Given this list of marker genes Chd3, Ermard, Mif4gd, Fmn2, Fos, Lypd1, Tm9sf3 (NCBI Gene Id 67221), Cep78, Plekhg1 (pleckstrin homology domain containing, family G (with RhoGef domain) member 1), Dnaaf9, Ccndbp1, Pisd-ps1, Tmem108, Cercam, Klhl5, Impa2, Itgb8, Shroom2, Mllt3, Mapre1, Elavl3, 1700028E11Rik, Kansl1, Bak1, Map1b, Eya3, Gm49083, Ppm1l, Cklf, Mical3, Tctn2, Cib1, Jun, Hdac9, Sox8, Slc41a2, Mir1949, Stat1, 1700047M11Rik, Pcdh19, Ebf4, Gnptab, Usp53, Pdk1, Foxp1, Tet2, Reno1, Cdh20, Ulk2, H1f2, Card19, D630045J12Rik, Grb14, Bfar, Plekhm3, Lrrc75a, Tyro3, Sorbs1, Rhobtb3, Nkd1, Gjc3, Smurf1, Thoc2l, Ddx23, Plpp6, Prkcq, Nkain1, Inava, Sec16b, Ninj2, Ankrd44, Hnrnpr, Rnf128, Ecpas, Syt1, Wwp2, Tmem63a, Atp6v1g2, H3c14, Trip11, Slc1a3, Ndufaf3, Nrtn, Fam174b, Sv2a, Ehd1, Eef1akmt2, Rbm25, Fam13c, Lats2, Svil, Pde4b, Amn1, Rcor2, Tmeff1, Pdgfc, Frmd4b, Epb41l1, Tpp2, Sdsl, Psmf1, Ifi27l2a, Prrc2c, Aar2, Mbnl2, Bmp1, Shb, Rnf144a, Ucp2, Ipo7, Snrpd3, Atat1, Kctd18, Slc45a4, Plekhn1, Gpr37, Hbp1, Mxi1, Nr1d2, Thtpa, Prune1 (NCBI Gene Id 77902), Atp1b2, Tcf12, Ift22, Kctd4, Bnip3, Zfp24 (zinc finger protein 24), Lman1, Ier5 (NCBI Gene Id 15939), Hand2, Wwp1, Gdi1, Chml, Htt, Mir100hg, Klhl29 (NCBI Gene Id 208439), Arhgap5, Frat2, Rbm12, Fbxo6, Cyfip2, Tmc7, Gnb4, Apba1 (NCBI Gene Id 56090), Gm20515, Efhd1, Rtn4, Map6, C1qtnf5, Rffl, Casp6, Myo1g, Sass6, Sgk2, Terf1, Ttbk1, Sat1, Sgpl1, Jcad, Dusp10, Bmerb1, Rttn, Igfbp7, Dalrd3, 1600012H06Rik, Mpv17, Soat1, Tnfrsf21, Ptprm, C4b (complement C4B (Chido blood group)), Sox21, Atg4a-ps, Bcas1, Tgfbr3, Lmbrd1, Rhog, Tbx2, Narf, Jak2, H2bc4, Foxp2, Ppp1r21, 9630013A20Rik (RIKEN cDNA 9630013A20 gene), Tmem8b, Tlk2, Mindy1, Cert1, Zbtb20, Tmem198b, Ostm1, Has2, Fam234b, Arhgef25, Fkbp8 (NCBI Gene Id 14232), Sdc2, Cnp, Dnajb14, Mau2, Pxdn, Mpdu1, Ndrg1, Ppp1r12b, Rabgap1l, Aldh3b1 (aldehyde dehydrogenase 3 family, member B1), Sae1, Ehbp1, Cela1, Ubfd1, Omg, Wrn, 1810037I17Rik (RIKEN cDNA 1810037I17 gene), Mutyh, Snorc, Apba2, Lgals9, Wipi1, Kdm5b, Rasgef1b, Pcdhb7, Cpt1a, Vps51, Slc15a4, Sap30bp, Lrrc42, Msi2, Tmco6, Frmd5, D16Ertd472e, Cadm1, Zfp809, Gen1, H4c9, Zfp637, Tmem88b, Dtna, Dock4, Cdv3, Baz2b, Amd-ps1, Pex1, Atp8a1, Ccng2 (NCBI Gene Id 12452), Lpgat1, Ldlrad3, Pkig, Tgs1, Smarca2, Mylk, Cyb5a, Pdzrn4, Mt3, Aopep, Deptor, Cfap410, Myo18a, Pvt1, Tmem35a, Tppp, Hira, Shisal1, Tnr, Slc16a7, Gdf1, Tmem150a (transmembrane protein 150A), Wdr35, Lhpp, Armc6, Cep192, C1galt1c1, Cdc37l1, Car14, Mdp1, Vwa5a, Inpp5e, Inppl1, Pcdhgc4, Rundc3a, Astn1, Wdfy1, Serpini1, Herpud2, Ccnt2, Slc30a1, Actb, S100a1 (NCBI Gene Id 99575), Coro1c, Pigg, Plxnc1, Gria2, Agpat4, Chpt1, Stxbp3, Mtmr4, Wdr1, 1700039M15Rik, Fbxo32, Cers6, Ptgds, Slc31a2, Abcd4, Syt4, 2610021A01Rik, Tcf7l2, Map4k5, H3c15, Sorbs3, Ccpg1, Atg13, Zdhhc12, Chic1, Unc5b, Invs, Kif13a, Srgap1, Fkbp15 (NCBI Gene Id 338355), Hmx2, Bche, Ssc5d, Slc26a2, Tmcc2, Ptpdc1, Ylpm1, Cpsf6, Pmel (premelanosome protein), Tmsb15l (NCBI Gene Id 399591), Tbc1d14, Plxnb1, Gmfb, Hspa4, Mapre3, Plxnb3, Txnip, Nbeal1, Marcks, Rictor, Col11a1, Brsk1, Kif3c, Kif1b, Sema4g, Marf1, Nav3, Abcc10, Mgme1, Rad54b, Creld1, Slc6a6, Fancb, Fbxo10, Col6a1, Srcin1, Aebp1, Stk11ip, Tmbim1, Dixdc1, Zscan29, Serinc5, Btg1, Pcmtd2, Mospd2, Sat2, Dcc (DCC netrin 1 receptor), Mark1, Hsdl2, Gm20300, Hip1r, Cers4 (NCBI Gene Id 67260), Dzip1, Syne1, Ccdc28a, Klf13, Tbc1d22a, Ezr, Pcdhb17, Prtg, Pard6g, Pfn2, Parp3, Depdc7, Mastl, Usp20, Slc25a42, Epb41l4b, Ralgps2 (NCBI Gene Id 98645), Reps2, Aspa, Phldb1, Spag4, Hey1, Coq8a, Lbp, Stmp1, Cpm, Pnisr, Nol4l, Map6d1, Wac, Fam241a, Skil, Acy3, Wls, Fam120aos, Ddhd1, Ccdc13, H2ac18 (H2A clustered histone 18), Dscam, Mob3b, Fam193a, Sft2d3, 4933427D14Rik, Myo6, Bfsp2, Itga7, Snx5, Enpp2, Sik1, Pdlim7, Matn2, Lcorl (NCBI Gene Id 338482), Tns1, Golph3l, Btbd17 (BTB domain containing 17), C630043F03Rik, Tmem80, Tmcc3, Malat1, Pex5, Abhd10, Cabin1, Arrdc3, Tpgs2, Prag1, Rapgef1, Rassf2 (Ras association (RalGDS/AF-6) domain family member 2), Syngr1, Kalrn, Hells, Bin3 (NCBI Gene Id 80552), Hs3st1, 4930452G13Rik, Zfhx3, Miga2, Tnrc6b, Tomm20, Sorl1, Serpinb8, Hectd4, Tmeff2, Tnfsf9, Abhd3, Jam2, Rbm18, Dipk1a, Reln, Ablim1 (actin-binding LIM protein 1), Lrig1, Prkar2a, Mbp, Tubb4a, Epha7, Pnn, Adgrl3, Dnmt3a, Eldr, Per3 (NCBI Gene Id 72717), Yipf4, Ercc1, Glrb, Negr1, Bcl2l12, Slc35a3, Efr3b, Coq3, Rusc1, Gatm, Nsd2, Lin54 (lin-54 DREAM MuvB core complex component), Tsc22d1, Ino80dos, Zfyve27, Gnao1, Atosb, Sgcb, Rtl8c, Dner, Glis2, Slc25a27, Trp53inp1, Cfl2, Pik3r3, Pigb, Serbp1, Bace1, Ikzf5, Dennd5a, Slc44a1, Cops9, Nasp, Fcgrt, Iqce (NCBI Gene Id 74239), Golga4, Wdr83, Klhl2, Entpd5, Tube1, C1ql3, Glis3, Capn6, Col6a2, Thsd7a, Elovl7, Klhl18, Gng7, Mfsd12, Hlf, Slc5a3, Rab40c, Mex3b (NCBI Gene Id 93845), Slc48a1, Snx30, Col16a1, 3110040M04Rik, Cdc42ep5, Cenpw, Antxr2, Gpr180, Cep295, Dnm3, Chmp1b, Htra3, Retreg1, Fgfr2, Akt3, Lrrc8c, Pde9a (NCBI Gene Id 18585), Sdc1 (NCBI Gene Id 20969), Mllt11, Phldb2, Rab3gap2, Col9a1, Prickle1, Ndnf (neuron-derived neurotrophic factor), Qpct, Padi2, Ncam2, Usp6nl, Pacs2, Vmac, Ltbp1 (NCBI Gene Id 77322), Kifc2 (NCBI Gene Id 223662), Adamts4, Mroh3, Slc13a4, Pip4k2c, Lhfpl6, Zdhhc14, Col27a1, Jrk, Ncan, Asic1, Mapt, Zeb2, Ankrd12, Arsb, Kcna1, Pdcd4, Zfp445, Ccsap, Snapin, F8a, Col4a6, Ncor1, Slc17a5, Ndor1, Nherf2, 6030400A10Rik, Gsk3b, Tcta, Fyn, Tnfaip6, Ado, Dusp8, Pdlim2, Sema5b, Kctd13, Aatk, Septin4, Mapk8ip3, Fmnl2, Smg5, Timp2, Arhgap42, 5430435K18Rik, Mpzl1, Dlgap4, Atxn7l2, Nmral1, Tra2a, Slc1a1, Slc22a23, Arl5b, Rab7b (RAB7B, member RAS oncogene family), Purg, Osbpl9, Arl4a, Reck (reversion-inducing-cysteine-rich protein with kazal motifs), Dbn1, Irgm1, Myrf, Dusp7, Tmem19, Cdc42ep3, Chadl, Crebrf, Chd4, Ulk1, Kank1, Ttc5, Csf1, Atf3, Dct, Ptprcap, Fbxl3, Mb21d2, Vps37b, Pisd-ps2, Dynlt3, Cryab, Ppp1r16b, Gipc1 (NCBI Gene Id 67903), Parm1, Galc, Dclk1, Samd5, Tmem94, Zkscan8, Kdm6a, Mmd2, Chn2, Nfkb2, Tent5a, Sox2ot, ENSMUSG00000144058, Bhlhe40, Tor4a, 2700049A03Rik (NCBI Gene Id 76967), Rbms1, Fhod3, Smim14, Sptlc2, H2bc6, Tm7sf3, Akap10, Clcn3, Ppp2r2a, Nopchap1, Ptpre, Ap5s1, Homer1, Sh3bp4, Hipk2, Nceh1 (neutral cholesterol ester hydrolase 1), Btrc, App, Cfap300, Abtb1, B3gnt2, Enpp5, Galnt11, Ddr1, Sec14l3, Bnip3l, Sox13, Lrrc8b, Sash1, Nhsl1, Fkbp7, Reep1, Plec, Rnasel, Atl1, Nlgn3 (NCBI Gene Id 245537), Ttyh1, Alcam, Axl, Mecp2, Syt11, Tango2 (transport and golgi organization 2), Prnp, Cacnb3, Ncald, Cadm2, Bmf, Pllp, Trio, Tmem14a, Rnf5, Brca1, Slc2a13, E330034G19Rik, Ranbp6, Lypd6, Qki, Hddc3, Ttyh2, Pnrc1, Lrrc49, Icmt, Pigk (NCBI Gene Id 66613), Klhl30, Gpr17, Gas7, Mafa, Ralgps1, Zmynd8, Cln8, Mon2, Mrpl15, Dennd6b, Nfasc, Wscd1, Dusp15, Lrfn4, Vdr, Dipk2a, Acaa1a, Cd81, Tpp1, Spin4, Mtcl2, Zfyve1 (NCBI Gene Id 217695), Mgat3, Retreg3, Timp3, P4ha1, H2bc21, Fbxo44, Tpbg, Lztfl1, Ap1s2, Pigo, Dscaml1, Ift70b, Pros1, Plp1, Kcna6, Dhrs1, Mad2l1 (MAD2 mitotic arrest deficient-like 1), H2ac25, Pdgfa, Tmem30a, Pigt, Zfp703, Agk, Plxdc2, Arhgap23, Pcnx1, Urm1, Nrcam, Vat1, Prkca, Cerk, Hacd2, 2010320M18Rik, 4930503E14Rik, Plk3, Iglon5, Ralgds, Elapor1, Fut9, Cacna2d1, Trim2, Atpaf1, Cfap68, Kcnip3, Ubash3b, Phyhipl, Rnd2, Rtn2, H2az2, Epb41l2, Slc25a24, Myo5b, Bbip1, Lipg, Tjap1, Map3k5, Ogt, Pigq, Tst, Mboat1, Shisa4, Scarb2, Cpne2, Gm11110, Dock9, Tcf7l1, Coro7, Igsf11, Clip3, Elf1, Flrt2, Ttll5, Afap1, Serpina3n, Tmem151a, Reep3, Neo1, Ak1, Col6a3, Polr1has, Emp3, 5031439G07Rik, Camsap2, Fam32a, Synpo, Cd9, Mmgt2, St8sia1, Ube2h, Clmn, Taf13, Zfp365, Uqcc3, Rbm5, Pdcd10, Nod1, Wasf1, Rab2b, Elmod2, Tubb3, Garem2, Adcy9, Mtmr10, Kirrel3, Flnb, Ccng1, Lpar1, H2bc27, Elavl1, Nfic, Vps37a, Zdhhc2, Eeig1, Atp13a2, Pak3, Ppp2ca, Tgds, Gm5817, Cdh10, Sptbn1 (NCBI Gene Id 268394), Focad, Zkscan1, Lrrc73, B4galt5, Coq10a, Bcas3, Jam3, Kidins220, Rtl8a, Cyld, Mboat2, Peli1, Rab11fip2, Klhl24, Acox1, Nav1, Alms1, Pink1, Taf11, Mr1, Slc25a10, Cbx7, Ppp2r2b, Ahr, Sesn3, Cubn, Col20a1, Pcdhb9, Dlk2, Maf, Lims2, Zfp1, Mpi, Itpr2, Ermp1, Rbbp6, Smpd2, Ptprz1, R3hcc1, Abcc5 (ATP-binding cassette, sub-family C member 5), Abca7, Ago4, Plxna3, Spsb1, Map2k4, Hdac5, Nfkbib, Rad18, Cdk5, Pls1, Tspan2, Dgka, Ttc39c, Srpk3, Ankrd28, Fa2h, Lin9, Nedd4l, Asap1, Lgals2, Npc2, Samd9l, Ino80b, Lsamp, Efcab7, Pramel12, Nlgn2, Pcdh17, Zmat1, Rftn2, Naga, Zscan26, Ctsk, Pcdhb16, Dst, H4c8, Arpc1b, Scamp2, Rap2a, Tcf4, Npc1, Plekha1, Srcap, Bri3bp (Bri3 binding protein), Col4a5, Lrp4, Zfr, Aamdc, Tbc1d8, Gab1, Cep95, Ophn1, Strada, Gadd45b, Notch1, Mfap3l, Tafa2, Cnih2, Svip, Xrn1, Calcoco1, Nhsl3, Gramd2b, Bcdin3d, Bcar1, Rufy3, Slc2a3, Igsf9b, Htra1, Cmtm6 (NCBI Gene Id 67213), Tex2, Amotl2, Lrrn3, Sapcd1, Coq8b, A930004J17Rik, Cnksr3, Cilk1, Man2b1, Pik3ip1, Entrep1, Mxd1 (NCBI Gene Id 17119), Cyp39a1, Dynll1, Grid2, Tgfb3, S100b, Socs3, Tmprss5, Mycbp, Cyp2j6, Lncppara, Acbd5, Dgat2, Dnmt3b (DNA methyltransferase 3B), Cyp2j9, Poc1b, E2f8, Fgfrl1, Cyrib, Kif21a, Tssc4, Phf21b, Dnajb4, Abhd12, Sh3d19, Dctn3, Ctsf, Cerox1, Tamalin, Nipal3, Deaf1, Ppt1, Dbp, Atp6v0a2, Gins3, Hadhb, Rnf187, Tmem51, Sirt2, Dab2, Id4, Cd82, Abca2, Tbc1d16, Sdf4, Mgll, Hr, Cnrip1, Pafah1b1, Katnal1, Zfp579, Gltp, Map1lc3b, Ddx25, Tcp11l2, Gal3st1, Fyco1, Sox4, Pcolce, Acsbg1, Add3, Ubxn8, Ercc4, Erbin, Nisch, Nrep, Rora, Vps50, Abi1, Col11a2, Hspa1b, Taf9b, Tulp4, Dock7, Camk2d, Mpp2, Coa8, Hacl1, Zfand5, Tmem106b, Mapre2, Prkar1b, Rgs3, Fzd8, Plppr5, Sema6d, 4933407L21Rik, Cep128, Rubcn, Ppara, Dpysl3, Tfeb, Mkrn1, Speg, Tmem216, Ttc39aos1, Ank3, Pak1, Tbc1d23, Tmem71, Ndrg4, Efcab14, Spats2l, Rfx5, Zfp386 (NCBI Gene Id 56220), Cdk19, Atrn, Cyth1, Specc1, N4bp2l1, Iffo1, Lsm11, Pkp4, Rsf1, Pspc1, Irs1, Mettl26, Atmin, Acaa2, Sned1, Nav2, Map1a, Ube2d-ps, Cpeb2, Arhgap28, Ccl5, Lhfpl2, Slc15a2, Sema4d, Socs6, Lrrc4c, Ypel3, Ehd2, Noxred1, Dbndd2, Helz, Brms1, Tmem40, Ugt8a, Pcdh7, Eps8, Scn8a, Katnal2, Kazn, Fam53b, Pxmp4, Inpp5k, Appl2, Ikzf2, Strn, here is a description of the gene set: Genes down-regulated during differentiation of Oli-Neu cells (oligodendroglial precursor) in response to PD174265. Inadequate remyelination of brain white matter lesions has been associated with a failure of oligodendrocyte precursors to differentiate into mature, myelin-producing cells. In order to better understand which genes play a critical role in oligodendrocyte differentiation, we performed time-dependent, genome-wide gene expression studies of mouse Oli-neu cells as they differentiate into process-forming and myelin basic protein-producing cells, following treatment with three different agents. Our data indicate that different inducers activate distinct pathways that ultimately converge into the completely differentiated state, where regulated gene sets overlap maximally. In order to also gain insight into the functional role of genes that are regulated in this process, we silenced 88 of these genes using small interfering RNA and identified multiple repressors of spontaneous differentiation of Oli-neu, most of which were confirmed in rat primary oligodendrocyte precursors cells. Among these repressors were CNP, a well-known myelin constituent, and three phosphatases, each known to negatively control mitogen-activated protein kinase cascades. We show that a novel inhibitor for one of the identified genes, dual-specificity phosphatase DUSP10/MKP5, was also capable of inducing oligodendrocyte differentiation in primary oligodendrocyte precursors. Oligodendrocytic differentiation feedback loops may therefore yield pharmacological targets to treat disease related to dysfunctional myelin deposition. Mouse Gene Set: GOBERT_OLIGODENDROCYTE_DIFFERENTIATION_DN species: Mus musculus from publication Gobert RP, Joubert L, Curchod ML, Salvat C, Foucault I, Jorand-Lebrun C, Lamarine M, Peixoto H, Vignaud C, Frémaux C, Jomotte T, Françon B, Alliod C, Bernasconi L, Abderrahim H, Perrin D, Bombrun A, Zanoguera F, Rommel C, Hooft van Huijsduijnen R (PMID 19139271)